Given this list of marker genes Map4k4, Frmd6, Stk3, Sox11, Iqschfp, Aars1, Prpf4b, Tial1, Coro7, Schip1, Stk4, Arrdc3, Ywhae, Dlg5, here is a description of the gene set: Mouse Gene Set: GOBP_POSITIVE_REGULATION_OF_HIPPO_SIGNALING Any process that activates or increases the frequency, rate or extent of hippo signaling. species: Mus musculus